Given this list of marker genes CR1, CBFB, IFNG, IL2, NFATC2, CTLA4, TNFRSF18, FOXP3, IL2RA, RUNX1, here is a description of the gene set: Human Gene Set: REACTOME_RUNX1_AND_FOXP3_CONTROL_THE_DEVELOPMENT_OF_REGULATORY_T_LYMPHOCYTES_TREGS species: Homo sapiens RUNX1 and FOXP3 control the development of regulatory T lymphocytes (Tregs)